Given this list of marker genes MAN1B1, NSUN2, TET3, LETM1, TCTN1, MRAS, MID2, SIN3A, RNU4-2, SLC18A3, TPM3, CLCN3, AGRN, POU4F1, IFT74, MTM1, APC2 (NCBI Gene Id 10297), RAB39B, AIP, CDC42BPB, SMS, TSPAN7, BCOR, KBTBD13, EYA1, PDE6D, SUFU, CHRNB1, PYROXD1, DDX3X, ACBD6, TBL1XR1, EXTL3, SCN4A, SETBP1, EBF3, CBY1, SELENON, RYR1, IFT56, KIAA0753, SLC12A6, TOGARAM1, COG3, SATB2, COMT, ATG7, PHF8, TMEM67, MSTO1, ADAT3, TMEM147, NONO, FAM149B1, SNX14, SIX1, RAI1, ASXL1, TBX1, TMEM237 (transmembrane protein 237), PPP1R12A, SOX6, GPR101, SLC9A7 (solute carrier family 9 member A7), SLC2A10, SETD2, SPEG, NPHP1, BIN1, CUX1 (cut like homeobox 1), NSDHL, ASPH, ARMC9, PPP2R5D, CCDC174 (NCBI Gene Id 51244), SLF2, SLC5A7, AGA, FBN1, FMR1, PMM2, TPRKB (TP53RK binding protein), ERCC6, CLCF1, TTN, B3GLCT, COL13A1, IDUA, PQBP1, RPGRIP1L, MAP3K20, CPSF3, UBE2A, HYLS1 (HYLS1 centriolar and ciliogenesis associated), MYH3, INPP5E, PBX1, HACD1, IQSEC2, MYO9A, MAP2K1 (NCBI Gene Id 5604), SPEN, SLC4A10, OCRL, BRAF, FLII, RECQL4, NFIA, SMAD2, PCGF2, MGP, TGFB3, KANSL1, SYNGAP1, NHS, ADNP, MOCS2, HNRNPK, UPF3B, NFIX, FRA10AC1, MAP2K2, BCR, OFD1, PTCH1, CRLF1, NEDD4L (NCBI Gene Id 93998), GALNT2, AHI1, SMAD3, UBAP2L, CHAT, NKAP, SYNE1, RIC1, TLK2, HRAS, ANKH, CTCF, CEP41, COL3A1, ERCC4, DDR2, SLC6A8, CSPP1, FGF3, STRADA, KLHL41, HNRNPH1, ATAD3A, CEP290, ERCC1, PAK1, STEEP1, BCORL1, TTC5, SYT2 (NCBI Gene Id 6858), FILIP1, ARL3, STT3A, ITGA7, ZFX, TONSL, ZNF423, OTUD6B, APC, KIF7, NBAS, FBXO11, NEB, MEIS2, DNM1, MAPRE2, C12orf57, CAMTA1, CHRNE, CAPRIN1, TMEM138, FLNB, PURA, SLC16A2, WNT7A, CLCN4, NRCAM, SNAP29, SEC24C, TAF1, RUSC2, AP1S2, TNNT1, PRKACA, SRCAP, UBE3B, KCNK9, FLNA, PRDX1, MOCS1, KATNIP, CEP120, ZNF711, BRAT1, CC2D2A, POC1A, HDAC4, RREB1, B9D1, ACTA1, HIRA, ARVCF, SCUBE3, BRWD3, DOCK3, TOPORS, SNAP25, MMACHC, TCTN3, MAPK1, PCDHGC4, PIGK, AKT1, KIAA0586, VAMP1, MED12, TMEM218, CEP57, TMEM231, EFEMP1, DEAF1, OPHN1, GFPT1, SGCG, DYRK1A, XRCC4, NF1, SOST, SLC9A6, DHX30, PIGU, CEP104, HUWE1, ERCC8 (ERCC excision repair 8, CSA ubiquitin ligase complex subunit), BCAS3, TMEM216, NSD1, PEX13, MYL2, HERC1, MAPK8IP3, RMRP, RAPSN, TPM2, MKS1, CRKL, PDE4D, SMC5, PRKACB, TCTN2, UFD1, NKX6-2, CHRNG, ATP7A, TCF20, CPLANE1, ASXL2, GRIN1, KAT6A, TP53RK, ALG12, POLA1, EIF2S3, PIBF1, KRAS, RPL10, CCDC115, SLC25A1, ALKBH8, KMT2B, ARL13B, NFIB, JMJD1C, GP1BB, TRAIP, MYPN, CHAMP1, B9D2, ANKRD11, here is a description of the gene set: Large face Human Gene Set: HP_LARGE_FACE species: Homo sapiens